Given this list of marker genes CREB3, ARGLU1, TLN1, LRMDA, TPT1, POLR3C, UBE2M, SERINC2, TSC22D1 (TSC22 domain family member 1), ZBTB33, TMUB1, GSK3B, KIRREL2, BCL11B, PIK3R2, C14orf119, UNC45A, AIP, RABEP2, PICALM, DARS1, SLC30A7, GATA3, PALS1, RBM24, CREB1, U2AF2, PTBP2, SPATS2, MED12, PRPF19, NDUFS1, CCAR2, RPS27, SPTAN1, ACIN1, EIF1B (eukaryotic translation initiation factor 1B), TSPAN6, LEF1, FOXO4, EEF1B2, EXTL2, BZW1, RNF115, WAC, CREBBP, CDC27, MTA2, here is a description of the gene set: from publication Xie X, Lu J, Kulbokas EJ, Golub TR, Mootha V, Lindblad-Toh K, Lander ES, Kellis M (PMID 15735639) species: Homo sapiens Genes having at least one occurrence of the highly conserved motif M100 CRGAARNNNNCGA in the regions spanning 4 kb centered on their transcription starting sites. The motif does not match any known transcription factor binding site. Comprehensive identification of all functional elements encoded in the human genome is a fundamental need in biomedical research. Here, we present a comparative analysis of the human, mouse, rat and dog genomes to create a systematic catalogue of common regulatory motifs in promoters and 3' untranslated regions (3' UTRs). The promoter analysis yields 174 candidate motifs, including most previously known transcription-factor binding sites and 105 new motifs. The 3'-UTR analysis yields 106 motifs likely to be involved in post-transcriptional regulation. Nearly one-half are associated with microRNAs (miRNAs), leading to the discovery of many new miRNA genes and their likely target genes. Our results suggest that previous estimates of the number of human miRNA genes were low, and that miRNAs regulate at least 20% of human genes. The overall results provide a systematic view of gene regulation in the human, which will be refined as additional mammalian genomes become available. Human Gene Set: CRGAARNNNNCGA_UNKNOWN